Given this list of marker genes Nf1, Abcc8, Dtnbp1, Stxbp1, Kcnj8, Kmo, Rab3gap1, Pak1, Slc38a2, here is a description of the gene set: species: Mus musculus Mouse Gene Set: GOBP_GLUTAMATE_SECRETION_NEUROTRANSMISSION The controlled release of glutamate by a cell, in which the glutamate acts as a neurotransmitter.